Given this list of marker genes KCNJ18, AIRE, CLCNKB, CACNA1S, GABRA3, TSHR, SLC12A3, here is a description of the gene set: studied in species Homo sapiens Human Gene Set: HP_THYROTOXICOSIS_WITH_DIFFUSE_GOITER Thyrotoxicosis with diffuse goiter